Given this list of marker genes BAZ1A, SMARCA5, C17orf49, RSF1, POLE3, SMARCA1 (NCBI Gene Id 6594), RBBP4, CECR2, BAZ2A, BPTF (bromodomain PHD finger transcription factor), RBBP7 (NCBI Gene Id 5931), CHRAC1, BAZ1B, LUZP1, HMGXB4, here is a description of the gene set: Any nuclear protein complex that contains an ATPase subunit of the imitation switch (ISWI) family. ISWI ATPases are involved in assembling chromatin and in sliding and spacing nucleosomes to regulate transcription of nuclear RNA polymerases I, II, and III and also DNA replication, recombination and repair. Human Gene Set: GOCC_ISWI_TYPE_COMPLEX species: Homo sapiens